The following is a description of a gene set: Human Gene Set: REACTOME_PI5P_REGULATES_TP53_ACETYLATION species: Homo sapiens PI5P Regulates TP53 Acetylation, and this is the list of marker genes: PIP4P1, PIP4K2B, TP53, MAP2K6, EP300, PIP4K2A, ING2, PIN1, PIP4K2C